The following is a description of a gene set: Human Gene Set: POU3F2_02 Genes having at least one occurrence of the motif TTATGYTAAT in the regions spanning 4 kb centered on their transcription starting sites. This matches the POU3F2 transcription factor binding site V$POU3F2_02 (v7.4 TRANSFAC). studied in species Homo sapiens, and this is the list of marker genes: OTX2, MTUS1, FAM50A, CCDC107, FSIP2, COL25A1, PLAG1, ZNF428 (NCBI Gene Id 126299), HS3ST4, ASPA, TOP1, FGF7, OR2W1, ZPLD1, ALKBH6, LRFN5, SLC18A3, OGDHL, ATOH1, ITSN1, CLRN1, SOSTDC1, ZSCAN20, DUSP5, MYT1, HDAC9, ANP32A, H2BC4, CABLES1, POU2F1, KRTAP6-1, PTCH1, UTP18, HIVEP3, SCN2A, ADGRL1, HOXB1, SLC24A3, ZBTB17, TSPYL2, CFAP20, ELMO1, RRAS, NEK10, SNCAIP, LOX, GPC4, ZNF827, H3C3, FERD3L, RREB1, NHSL2, ASXL1, NRAS, C6orf62, OLFML2B (olfactomedin like 2B), BMI1, NFIX, KRT83, H2BC3, NEIL3, HOXB9, PDE3B, TFB2M, FOXP2, DCN, SKIDA1, SALL3, RANBP3L, LCOR, ADM, DPYD, SYT1, HS6ST3, IRAK1, HOXD10, MAF, ING1, PCDH8, ADNP, ACTG2, PRRC2A, XYLT2, H2AC6, GBX2, LINC01164, NEO1, LMO4, EYA1, KRT28, NEUROG2, PDGFA, TEAD3, LHX6, TBXAS1, TNNI1 (NCBI Gene Id 7135), SLC22A17, DIXDC1, CXADR, HEPACAM, TFAP2C, MTF1, GSX1, PRDM10, SMARCA2, HOXD11, SCRN1, C17orf58, ZEB2, RAB6C (NCBI Gene Id 84084), GPR85, PRDX2, FKRP, HPCAL4, PTEN, UNC13D, CHAT, TENT4B, PIK3R1, PKD2L2, SLC6A15, PNISR, GOLPH3L, TAPBP, MYF5, ANKRD11, NUFIP2, BRS3, RP1, CUX1, EMILIN3, BMP5, BBX, FGF20, CXXC5 (NCBI Gene Id 51523), HSD3B7, H3-3B (H3.3 histone B), MTMR4, SPATA31H1, CCDC80, ERRFI1, ESRRA, SP6, MEF2C, SAMD11, NPTX2, GAS2, SDHAF2, ATF7IP, KCNK2, SFRP2, ENAM, ZNF516-DT, PHC2 (polyhomeotic homolog 2), FRMD4A, ZIC4, AP1S2, KALRN, FOXP1, CHST7, TBC1D19, HOXD9, SOBP, CAMSAP2, PAK1IP1, MITF, TAMM41 (TAM41 mitochondrial translocator assembly and maintenance homolog), LMNA, TFAP2D, GTPBP1, ERG, POU1F1, STRN4, PIK3C2A, PDZRN4, CSF3, DNAH7, HOXC6, ZNF423, AGTR2, CDH13, CDK11B, ADD3, MUSK, RARB, BRD8, HTR4, ZSCAN21, NUDT3, KCNT2, VSIG1, IL1RAPL1, PLCD4, SIX1, HOXA4, GSC, BST2, BARHL2, SLC26A7, PTGR3, UBB, RCAN1, PHF3, NOL4L, PPP2R2B, GPR21, DLX1, CYP4B1, CADM2, LGI1, RAB3C, FBXW11 (F-box and WD repeat domain containing 11), ABL1, SEMA3A, DSG1, ATP13A4, LIPG, MOSMO, BMPR2, OSER1 (oxidative stress responsive serine rich 1), MAL2, NPVF, DGKG, SATB1, GABRG2, GIP, HOXC4, MAP2K5, SUPT16H, RASGEF1B, HOXA3, ISL1, ATP6V0C, SRSF7, CDK11A (NCBI Gene Id 986), CPSF7, RBPJ, KRT85, PNMA1, GDI1, NXT2, CSRNP3, SCUBE3, MAGED2, PANK4, TMTC2, CACFD1, CADM1, ASXL2, CRYZL1, KRTAP11-1, BCOR, NRG4, CHCHD7, LYST, PSMA1, PCNX4, PBX3, XIAP, TOP3B, MIR17HG, GCM1, SHH, MDM1, CCN1, NEUROG1